Given this list of marker genes TNNC1, MYOZ2, MIR20A, MIR499A, FOXO1, MIR34C, TCAP, ACACB, MIR25, MYH6, ERRFI1 (NCBI Gene Id 54206), CAMTA2, APLNR, LMNA, BMP10, MSTN, TRIM63 (NCBI Gene Id 84676), MYOG, IGFBP5, MYOD1, MIR199A1, MIR17, TNNT1, SMAD3, ASB2, MIR208B, MIR208A, MLIP, GSN, MIR214, CACNA1S, MYOZ1, ATP2A2, PPARG, CFLAR, KLF15, MIR34B, SMAD4, TRPC3, CAMK2B, MYOC (myocilin), INPP5F, MYMK, HDAC4, HEY2, MYH7, ATP2B4 (NCBI Gene Id 54594), TNNI1, NPPA, KDM4A, CAMK2G, PPP3CA, ACTN3, EZH2, GATA6, GTF2IRD1, here is a description of the gene set: studied in species Homo sapiens Human Gene Set: GOBP_STRIATED_MUSCLE_ADAPTATION Any process in which striated muscle adapts, with consequent modifications to structural and/or functional phenotypes, in response to a stimulus. Stimuli include contractile activity, loading conditions, substrate supply, and environmental factors. These adaptive events occur in both muscle fibers and associated structures (motoneurons and capillaries), and they involve alterations in regulatory mechanisms, contractile properties and metabolic capacities.